The following is a description of a gene set: Right ventricular dilatation studied in species Homo sapiens Enlargement of the chamber of the right ventricle, which can be defined echocardiographically as a right ventricular to left ventricular ratio greater than 1:1. Human Gene Set: HP_RIGHT_VENTRICULAR_DILATATION, and this is the list of marker genes: MYH6, ACTC1, TRAPPC11, FNIP1, SGCG, TLL1, IPO8 (importin 8), CDH2, CITED2, GATA4, CTNNA3, TBX20, GATA6, NKX2-5, EFEMP2, ALG9, SCN5A